The following is a description of a gene set: Atrophy of the muscles of the pelvic girdle (also known as hip girdle), i.e., the gluteal muscles, the lateral rotators, the adductors, the psoas major and the iliacus muscle. Pelvic girdle amyotrophy species: Homo sapiens Human Gene Set: HP_PELVIC_GIRDLE_AMYOTROPHY, and this is the list of marker genes: CAPN3, SMN2, GYG1, VCP (valosin containing protein), SMN1